The following is a description of a gene set: species: Homo sapiens The presence of developmental dysplasia of the nail. Human Gene Set: HP_NAIL_DYSPLASIA Nail dysplasia, and this is the list of marker genes: BMP4, FHL1, IL11RA, KRT6B, POP1, PIGV (NCBI Gene Id 55650), DVL1, TAF1, TMPRSS6, WNT5A, NXN, TGM1, ERCC2, TERT, WNT10A, EFNB1, TRRAP, IKBKG, NECTIN1, LETM1, TRPV3, AARS1, FGFRL1, PHYH, KRT5, PRKACB, SLC24A4, EOGT, GJB6, ORC1, PIEZO1 (NCBI Gene Id 9780), RNF113A, HRAS, FLT4, CARS1, SHANK3, CDH1, TP63 (NCBI Gene Id 8860), ATP6V1B2, EDA, RLIM, KRT1, WNT7A, FZD6, PEX7, ANTXR1, GLI3 (NCBI Gene Id 2737), FGF10, NSD1, SETBP1, PLEC, IFT43, GJC2 (NCBI Gene Id 57165), BMP2, SMARCD2, WDR35, GPC4, SOST, STIM1, IHH, LRP4, LAMA3, GPC3, DKC1, GLI1, CLEC7A, KCTD1, SIN3A, POC1A (NCBI Gene Id 25886), INSR, FGFR3, ERCC3, SUZ12, SATB2, EXT2, LAMB3, SREBF1, ERI1, HOXC13, ANAPC1, RECQL, AHDC1, CTC1, TRAF3IP2, GTF2H5, SRY (sex determining region Y), POMP, TINF2, PLCD1, ROR2, ARX, KRT6A, ECE1, FGFR2, ITGB4, HHAT, LMX1B, EVC, IL17RC, STXBP1, MSX1, DVL3, COL7A1, MPLKIP, CTSK, ANGPT2, BHLHA9, TRPS1, FZD2, RIPK4, KRT17, CPLX1, PORCN, DPM1, MBTPS2, GJA1, ABCA1, H3-3B, KRT14, TCF4, TFAP2A, VEGFC, PLOD3, KRT86, RNF13, RNU4ATAC, KRT16, FLNA, EZH2, HPGD, KRT85, GJB2, FAM111B, IL17RA, DYNC2LI1, IL17F, TBC1D24, PRKACA, RPS6KA3, NSD2, ALG3, NTRK1, TARS1, PTDSS1, CTBP1, GTF2E2, LAMC2, NFKB2, RECQL4, CTNND1, ZFX, EVC2